The following is a description of a gene set: Human Gene Set: HALLMARK_WNT_BETA_CATENIN_SIGNALING Genes up-regulated by activation of WNT signaling through accumulation of beta catenin CTNNB1. studied in species Homo sapiens from publication Liberzon A, Birger C, Thorvaldsdóttir H, Ghandi M, Mesirov JP, Tamayo P (PMID 26771021), and this is the list of marker genes: DVL2, PPARD, HDAC5, FZD1, WNT6, JAG2, KAT2A, FRAT1, RBPJ, ADAM17, JAG1, HEY2, MYC, NOTCH1, NOTCH4, DKK4, WNT1, HDAC2, SKP2, TP53, NKD1, NCSTN, GNAI1, LEF1, HDAC11 (NCBI Gene Id 79885), FZD8, PSEN2, WNT5B, AXIN2, DLL1, TCF7, NUMB, CTNNB1, HEY1, NCOR2, AXIN1, PTCH1, CCND2, DKK1, CUL1, MAML1, CSNK1E